The following is a description of a gene set: studied in species Homo sapiens Human Gene Set: GOMF_N_METHYLTRANSFERASE_ACTIVITY Catalysis of the transfer of a methyl group to the nitrogen atom of an acceptor molecule., and this is the list of marker genes: NNMT, SETD7, ASH1L, KMT5C, METTL18, MECOM, SUV39H1, EEF1AKMT2, CARM1, SETD3, PRMT5, NDUFAF7, CSKMT, EHMT2, FAM86B1 (NCBI Gene Id 85002), SETD2, ATPSCKMT, METTL22, SUV39H2, SETMAR, DOT1L, FBL, PRDM8, FAM86B2, PRDM16, KMT2B, EEF2KMT, EZH1, PRDM7, FBLL1, PEMT, CAMKMT, THUMPD3, PRDM2 (PR/SET domain 2), NSD3, SETD1A, FBXO11, METTL5, PRMT1, NSD1, EEF1AKMT3, JARID2, WDR5, TFB2M, KMT2D, SMYD2, PRMT7, TTLL12, METTL13, KMT5A, PRDM9, SETD1B, PRMT8, ETFBKMT, PRMT3, SETD4, DIMT1, METTL21A, N6AMT1, METTL21C, SETD9, PRMT2, PRMT6, HNMT, SETDB2, METTL15, ZCCHC4, PRDM6, TFB1M, TRMT1, HEMK1, NSD2, PRMT9, KMT2C, KMT2A, SETD6, TRMT11, GNMT, RNMT, KMT5B, SETD5, PNMT, METTL23, EEF1AKMT4, METTL9, VCPKMT, SMYD3, METTL15P1 (methyltransferase like 15 pseudogene 1), FDXACB1, INMT, EZH2, SPOUT1, ANTKMT, METTL25B, SMYD1, SETBP1, SETDB1 (SET domain bifurcated histone lysine methyltransferase 1), EHMT1, SMYD5, EEF1AKMT1